Given this list of marker genes Htr4, Htr7, Htr5a (NCBI Gene Id 15563), Htr6, Htr1d, Htr2a, Htr1b, Htr1f, Htr2b, Htr1a, Htr2c, here is a description of the gene set: Serotonin receptors species: Mus musculus Mouse Gene Set: REACTOME_SEROTONIN_RECEPTORS